The following is a description of a gene set: from publication Turashvili G, Bouchal J, Baumforth K, Wei W, Dziechciarkova M, Ehrmann J, Klein J, Fridman E, Skarda J, Srovnal J, Hajduch M, Murray P, Kolar Z (PMID 17389037) Genes up-regulated in ductal carcinoma vs normal ductal breast cells. species: Homo sapiens Human Gene Set: TURASHVILI_BREAST_DUCTAL_CARCINOMA_VS_DUCTAL_NORMAL_UP BACKGROUND: Invasive ductal and lobular carcinomas (IDC and ILC) are the most common histological types of breast cancer. Clinical follow-up data and metastatic patterns suggest that the development and progression of these tumors are different. The aim of our study was to identify gene expression profiles of IDC and ILC in relation to normal breast epithelial cells. METHODS: We examined 30 samples (normal ductal and lobular cells from 10 patients, IDC cells from 5 patients, ILC cells from 5 patients) microdissected from cryosections of ten mastectomy specimens from postmenopausal patients. Fifty nanograms of total RNA were amplified and labeled by PCR and in vitro transcription. Samples were analysed upon Affymetrix U133 Plus 2.0 Arrays. The expression of seven differentially expressed genes (CDH1, EMP1, DDR1, DVL1, KRT5, KRT6, KRT17) was verified by immunohistochemistry on tissue microarrays. Expression of ASPN mRNA was validated by in situ hybridization on frozen sections, and CTHRC1, ASPN and COL3A1 were tested by PCR. RESULTS: Using GCOS pairwise comparison algorithm and rank products we have identified 84 named genes common to ILC versus normal cell types, 74 named genes common to IDC versus normal cell types, 78 named genes differentially expressed between normal ductal and lobular cells, and 28 named genes between IDC and ILC. Genes distinguishing between IDC and ILC are involved in epithelial-mesenchymal transition, TGF-beta and Wnt signaling. These changes were present in both tumor types but appeared to be more prominent in ILC. Immunohistochemistry for several novel markers (EMP1, DVL1, DDR1) distinguished large sets of IDC from ILC. CONCLUSION: IDC and ILC can be differentiated both at the gene and protein levels. In this study we report two candidate genes, asporin (ASPN) and collagen triple helix repeat containing 1 (CTHRC1) which might be significant in breast carcinogenesis. Besides E-cadherin, the proteins validated on tissue microarrays (EMP1, DVL1, DDR1) may represent novel immunohistochemical markers helpful in distinguishing between IDC and ILC. Further studies with larger sets of patients are needed to verify the gene expression profiles of various histological types of breast cancer in order to determine molecular subclassifications, prognosis and the optimum treatment strategies., and this is the list of marker genes: CENPF, SULF1, KPNA4, CLHC1, COL4A1, COL10A1, EPB41L3, FSIP1, POSTN (periostin), COL5A2, TOP2A, FBN1, LRRC15 (leucine rich repeat containing 15), SFRP2, FN1, DTL, DCLK1, GDPD1, LUM (lumican), PNP, TXNDC9, CD44, COL3A1, UBE2D1, NCK1, LINC01614, TLR7, EDEM3, ASPN, EIF2AK1, DNAJC21, SGO2, COL11A1, VCAN, COL1A2, ZNF571, FAR2, COL1A1, ALG13, DGKH, MBTPS2, DDX60, UNC5B, RET, TRIM59, CKS2, RRP15